The following is a description of a gene set: Mouse Gene Set: HELLS_TARGET_GENES Genes containing one or more binding sites for (Hells) in their promoter regions (TSS -1000,+100 bp) as identified by GTRD version 20.06 ChIP-seq harmonization. from publication Yevshin I, Sharipov R, Kolmykov S, Kondrakhin Y, Kolpakov F (PMID 30445619) studied in species Mus musculus, and this is the list of marker genes: Zfp750, Prelid3a, Ring1, Elf1, Mphosph9, Rab1a, Taco1, 4833418N02Rik, Tns3, 1600020E01Rik, Ptbp2, Map4k4, Cpsf1, I830077J02Rik (RIKEN cDNA I830077J02 gene), Anapc15, Nlrp3, Smad7, Mapk14, mt-Tp, Cdhr2, Dlec1 (NCBI Gene Id 320256), Antkmt, Yap1, Srrt, Strip2, Slit2, Cd164, Hus1b, Sfr1, Zdhhc6, Gm29328, Cep70, Eif4g2 (eukaryotic translation initiation factor 4, gamma 2), Atr, Phlda3, Mtrfr (mitochondrial translation release factor in rescue), Mkx, Mat2a, Uap1, Tsen15, Dusp28, Etfdh, Map2k5, Edf1, Pex13, Pus10, Acox1, Map2k2, Alg9, Mrpl18, 1700065D16Rik, A630023A22Rik, Wbp4 (WW domain binding protein 4), Ttc7, Trmt11, Glul, Zfp62, Sp4, Septin10, Dtwd1, Setd2, Ap1g1, Rpl21-ps1, 9130213A22Rik, Cdkn2aipnl, Dock9, Rhot1, Prss36, Ddx39b, Sowahc, Pcbp1, Fbxo34, Zfp24, Gm22589, Mir219c, Slc25a18, Tcp1, Fam227b, Otub2, Thsd7b, Asph, Ptges3, Raf1, Tmem169, Ist1, Stk11ip, Nuf2, Cul5, Vti1a, Cbx1, Eif1-ps3, Utp3, Teddm2, Adnp, Cops4, Cdca4, Gm32200, Pms2, Gm15889, Setx, Lypla1, Wdfy1, Tfrc, Tbrg4, Nufip2, Sgk2, Zfp710, Dnaja1, Gm5464